The following is a description of a gene set: studied in species Homo sapiens Genes predicted to be targets of miRBase v22 microRNA hsa-miR-649 in miRDB v6.0 with MirTarget v4 prediction scores > 80 (high confidence targets). Human Gene Set: MIR649 from publication Chen Y, Wang X (PMID 31504780), and this is the list of marker genes: GAPVD1 (NCBI Gene Id 26130), RFX7, SLC2A4RG, ATP5IF1, ZNF281, COPS7B, KMT5A, STT3A, DCTN4, XIRP2, RAP1B, ACER3, VGLL4, UBE2E2, SNRPD1, KITLG, CORIN, SPTY2D1, ARFGEF1, RFPL1, CPNE4, MOB1B, MEX3C, DENND1B, KPNA1, NDUFA5 (NADH:ubiquinone oxidoreductase subunit A5), CHRDL1, P3H2, AKIRIN2, MARK3, CDK1, CFAP418, ZNF595, RPRD1A, BACH2, NEUROD6, MRPL43, CHL1, ARHGAP32, DICER1, CKAP2, API5, DNAAF6, INPP5K, STAG2, MYOT (NCBI Gene Id 9499), CCNG2, MLANA, TFCP2, PHC3, CACNA1H, KDM7A, GALNTL6, CCDC88A, RAB14, ARID4B, LHX6, BICRAL, NAA20, CCDC6, SPRED1, VCF1, DIPK2A, CAND1, MARK1, ZC3H12C (NCBI Gene Id 85463), TMEM181, NUFIP2, SENP5, ARID2, PHLDB2